Given this list of marker genes CHD7, SLC24A4, NTRK1, PLXNA3, CNGB1, SALL1, PLXNA1 (NCBI Gene Id 84202), here is a description of the gene set: species: Homo sapiens Human Gene Set: GOBP_OLFACTORY_NERVE_DEVELOPMENT The process whose specific outcome is the progression of the olfactory nerve over time, from its formation to the mature structure. The olfactory nerve is a collection of sensory nerve rootlets that extend down from the olfactory bulb to the olfactory mucosa of the upper parts of the nasal cavity. This nerve conducts odor information to the brainstem.